Given this list of marker genes MXRA7, ADAM15, CACNA1G, TOP2A, CLPTM1, RPL29P12, MEF2C, PDGFRL, SPAG9, H2AC25, BLTP1, ACACA, FDXR, PPL, ISG15, ABAT, ARMC9, STAT1, FHL1, LRRC23, GMPR, RABL2B, CPD, RCN3, NEFL, TMEM47, H2BC8, SLC17A7, TSPAN13, CRIP2, TSPAN4 (tetraspanin 4), SNRNP70, CEP131, L1CAM, CTTN, PRPH, CDC34, CDK10, NEDD9, ZNF556, IDI1, MGST3, SYT11, TAOK3, CSRP2, CRK, NUDT11, H2AC13, H2AC17 (NCBI Gene Id 8336), BIRC3, SFXN3, FTL, PRDX2, WDR19, GATA4, TRIP6, CYP1A1, FN1, BEX4, LZTS3, TMEM259, ZZEF1, DOCK6, HLA-DPA1, CXCL10, CDC20, PFN2, CDKN1A, H2AC6, MSH5 (mutS homolog 5), MICALL2, ITGA7, TCAF1, GSDMB, SEZ6L2, KLHL24, RAB4B, NRGN, H4C8 (NCBI Gene Id 8365), DBN1, ANKZF1, CDR2L, HLA-DRB4, SERPINI1, DNM3, APLP2, SNTA1, PLEC, S100A4, CDKN2D, GSTM4, ASMTL, PPARD, MAPKAPK2, GPM6A, NCOA2, SLC9A1, ZER1, BMP2K, PRKCB, BLVRB, KDM5B, H2AJ, MYRF, GPSM2, SH3GL3, MACROH2A1, ADCY9, IFT140, COTL1, UBD, FTCD, VCL, LLGL2, SGK3, TTLL1, ATP13A2, RALGPS1, STARD3, ACSBG1, SPAG6, MARK2, BBLN, HMG20B, JUNB, CADM4, H2AZ2, MAPK8IP1, KIF4A, MT1E, TYK2, RUNDC3B, FER (NCBI Gene Id 2241), ANKRD6, BAIAP3, MT2A, CDKL3, ZBTB43, CALCOCO1, MYO9B, TOP3B, PLPPR2, ARG2, PEG10, ING1, H3-3B, CENPE, FAM20C, AGRN, ZBBX, DNM2, PIK3CD, SORBS1, TMEFF1, VRK3, RAD9A, HPSE (heparanase), CGREF1, H3C10, GLYR1, H2AC14, TXNIP, DDAH2, PRKAR2B, NCAM1 (neural cell adhesion molecule 1), CLTC, HERC1, ALDOC, DLGAP5, EFHC1, LPCAT3, PPP2R3B, SEPTIN4, ZCCHC24, TUBB2B, SFI1, HES1, TUFT1, UQCRFS1, WASF1, PTGER4, CENPF, CYRIA, PPM1E, H1-0, SCML1, CFH, LONP2, CCHCR1, PLK2, MAOA, GLCE, GM2A, PTENP1, CHCHD7, HLA-DPB1, MSX1, MAN1B1, SMARCD3, NEU1, ACSL3, G6PD, CYP46A1, PMEL, GAGE2A, GPAA1, HSPA2, PDE4DIP, BIRC5, GRN, KATNB1, IFI6, HCFC1R1, SDC4, SPINK2, H2AC8, ATP6V0D1, TK1, MT1F, DOCK9, JUP, RNF128, MBTD1, RRAS, BCL6, HBA2, H3C2, ADARB1, SLC25A28, EPAS1, DAPK3, PLD3, MFSD12, POR, CDKN1C (NCBI Gene Id 702), ID2, H2AC11 (NCBI Gene Id 8969), PDLIM7, SHTN1, TSPAN12, TIMP3, TST, DENND5A, GSN, ENPP2, RNASE4, CDC37, IFIT1, FGFR4, H4C12, IFT122, ABHD17A, ATG4B, TUBB2A, SLC6A8, TUBA1A, HDAC3, EHBP1L1, H3C4, H2BC21, SAT1, TMSB15A, SOX4, APLP1, ENAH, CAMTA1, SELENOP, KHK (NCBI Gene Id 3795), SLC16A3, DPM3 (NCBI Gene Id 54344), AKAP12, MARCKSL1, CCNF, RTN2, AKR1C3, NR4A2, NRTN, FSCN1, DLX2, LIMA1, ZBTB20, NCOA3, DHRS2, KLF2, PAGR1, LAMP3 (NCBI Gene Id 27074), H1-10, ALDH4A1 (NCBI Gene Id 8659), HBA1, GNS, H2AC18, RADX, PCSK1N, SLC4A8, AASS, H4C9, ANKRD13C-DT, MT1X, HLA-DRB1, DNAAF11, ZSWIM8, PIGV, IL13RA1, NEAT1, H3C12 (NCBI Gene Id 8356), BRWD1, CD9, PLXNA3, JAG2 (NCBI Gene Id 3714), MT1H, NAALAD2, SEC23IP, ITGA6, MLF1, NCAPD2, SBF1, PTTG1IP, here is a description of the gene set: Human Gene Set: HELLER_HDAC_TARGETS_UP from publication Heller G, Schmidt WM, Ziegler B, Holzer S, Müllauer L, Bilban M, Zielinski CC, Drach J, Zöchbauer-Müller S (PMID 18172295) Genes up-regulated in at least one of three multiple myeloma (MM) cell lines by TSA. To identify epigenetically silenced cancer-related genes and to determine molecular effects of 5-aza-2'-deoxycytidine (Aza-dC) and/or trichostatin A (TSA) in multiple myeloma (MM), we analyzed global changes in gene expression profiles of three MM cell lines by microarray analysis. We identified up-regulation of several genes whose epigenetic silencing in MM is well known. However, much more importantly, we identified a large number of epigenetically inactivated cancer-related genes that are involved in various physiologic processes and whose epigenetic regulation in MM was unknown thus far. In addition, drug treatment of MM cell lines resulted in down-regulation of several MM proliferation-associated factors (i.e., MAF, CCND1/2, MYC, FGFR3, MMSET). Ten Aza-dC and/or TSA up-regulated genes (CPEB1, CD9, GJA1, BCL7c, GADD45G, AKAP12, TFPI2, CCNA1, SPARC, and BNIP3) were selected for methylation analysis in six MM cell lines, 24 samples from patients with monoclonal gammopathy of undetermined significance (MGUS), and 111 samples from patients with MM. Methylation frequencies of these genes ranged between 0% and 17% in MGUS samples and between 5% and 50% in MM samples. Interestingly, methylation of SPARC and BNIP3 was statistically significantly associated with a poor overall survival of MM patients (P = 0.003 and P = 0.017, respectively). Moreover, SPARC methylation was associated with loss of SPARC protein expression by immunostaining in a subset of MM patients. In conclusion, we identified new targets for aberrant methylation in monoclonal gammopathies, and our results suggest that DNA methyltransferase and histone deacetylase inhibition might play an important role in the future treatment of patients with MM. species: Homo sapiens